Given this list of marker genes PLA2G7, USP13, CCL11, FABP3, KRT7, CDKN2C, IFIT3, FABP4, RNASEL (NCBI Gene Id 6041), TIMP2, FN1, FBLN1 (NCBI Gene Id 2192), ACTC1, MMP7, APOD, BCL2A1, PSMB8, C1QA, LTC4S, C4B, MME, GPX3, PPARG, IGKC, ADIPOQ, SFTPD, AGTR1, TYROBP, IGHM, RXRG, PLAAT3, CYBB, CD36, WFDC2, C3, EPHA4, CASP1, CCN3, CFH, MBP, IBSP, CD74, TGFBR2, SERPINB1, ARG1, CTSK, FUS, CTSS, SIM2, TIMP4, LTBP2, PSMB10, TNC, ABCB4, NID1, LEP, SERPINA3, IRF1, PLOD2, PITX2, TNFSF13B, SAT1, TAC1, TNFSF10, ITGB2, PLAT, LGALS3, SPP1, ITGB6, CCND2, GBP2, PLEKHB1, ARHGDIB, AMD1, HPR, TLR2, TAP1, GPNMB, LTF, IGF1, PSMB9, TGM2 (NCBI Gene Id 7052), CD1D, STAT1, HDAC9, KLK3, FCER1G, LILRB3, EDNRB, here is a description of the gene set: Our previous study revealed that Vav3 oncogene is overexpressed in human prostate cancer, activates androgen receptor (AR), and stimulates growth in prostate cancer cells. The purpose of this study is to further determine the potential role of Vav3 in prostate cancer development in genetically engineered mouse model. We generated Vav3 transgenic mice by targeted overexpression of a constitutive active Vav3 in the prostatic epithelium. We found that overexpression of Vav3 led to development of mouse prostatic intraepithelial neoplasia and prostate cancer at the age of as early as 3 months. The AR signaling axis and phosphatidylinositol 3-kinase-Akt signaling were elevated in the prostate glands of Vav3 transgenic mice. In addition to prostate cancer, Vav3 transgenic mice developed significant nonbacterial chronic prostatitis in the prostate gland with notable infiltration of lymphomononuclear cells (monocytes, lymphocytes, and plasma cells), which was associated with elevated incidence of prostate cancer. DNA microarray and signaling pathway analysis revealed that the top diseases and disorders were inflammatory diseases and cancer of the prostate gland in Vav3 transgenic mice. In vitro analysis showed that overexpression of Vav3 in prostate cancer cells enhanced nuclear factor-kappaB (NF-kappaB) activity, implicating an underlying mechanism of innate inflammatory response induced by elevated Vav3 activity. These data showed that Vav3 overexpression in the prostate epithelium enhanced both the AR signaling axis and NF-kappaB-mediated pathway, which potentially contributed to the development of nonbacterial prostatitis and prostate cancer. from publication Liu Y, Mo JQ, Hu Q, Boivin G, Levin L, Lu S, Yang D, Dong Z, Lu S (PMID 18676865) Human Gene Set: LIU_VAV3_PROSTATE_CARCINOGENESIS_UP Selected genes up-regulated in prostate tumors developed by transgenic mice overexpressing VAV3 in prostate epithelium. species: Homo sapiens